Given this list of marker genes GRB2, STAT3, CEP43, FGFR1OP2, PIK3R1, CNTRL, LRRFIP1, CPSF6, BCR, MYO18A, TRIM24, GAB2, STAT5A, STAT1, STAT5B, ZMYM2, CUX1, PIK3CA, here is a description of the gene set: Reactome Pathway: Signaling by cytosolic FGFR1 fusion mutants part of: FGFR1 mutant receptor activation 8p11 myeloproliferative syndrome (EMS) is an aggressive disorder that is associated with a translocation event at the FGFR1 gene on chromosome 8p11. Typical symptoms upon diagnosis include eosinophilia and associated T-cell lymphoblastic lymphoma; the disease rapidly advances to acute leukemia, usually of myeloid lineage. At present the only effective treatment is allogenic stem cell transplantation. <br><br>At the molecular level, EMS appears to be caused by translocation events on chromosome 8 that create gene fusions between the intracellular domain of FGFR1 and an N-terminal partner gene that encodes a dimerization domain. The resulting fusion protein dimerizes in a ligand-independent fashion based the N-terminal domain provided by the partner protein and stimulates constititutive downstream FGFR1 signaling without altering the intrisic kinase activity of the receptor. To date, 11 partner genes have been identified: ZMYM2, FGFR1OP, FGFR1OP2, HERVK, TRIM24, CUX1, BCR, CEP110, LRRFIP1, MYO18A and CPSF6, although not all have been functionally characterized. <br>Where examined, cell lines carrying FGFR1 fusion genes have been shown to be transforming and to support IL3-independent proliferation through anti-apoptotic, prosurvival pathways. Signaling appears to occur predominantly through PLCgamma, PI3K and STAT signaling, with a more minor contribution from MAPK activation. Because the fusion proteins lack the FRS2-binding site, the mechanism of MAPK activation is unclear. Recruitment of GRB2:SOS1 through recruitment of SHC is one possibility. studied in species Homo sapiens